The following is a description of a gene set: Human Gene Set: GOBP_POSITIVE_REGULATION_OF_DENDRITIC_SPINE_DEVELOPMENT Any process that increases the rate, frequency, or extent of dendritic spine development, the process whose specific outcome is the progression of the dendritic spine over time, from its formation to the mature structure. species: Homo sapiens, and this is the list of marker genes: IL1RAPL1, DLG5, MAPK6, CPEB3, ITSN1, CAMK1, ZMYND8, CFL1, MAPKAPK5, SHANK1, CAPRIN2, APOE, EPHB2, RELN, BAIAP2, NLGN1, GPRASP3 (NCBI Gene Id 80823), PTPRD (NCBI Gene Id 5789), FMR1, CAPRIN1, NLGN2 (neuroligin 2, NCBI Gene Id 57555), STAU2, IL2, ARMCX5-GPRASP2, NEURL1, EEF2K, LLPH, C21orf91, RAC1, PSEN1, SHANK3, LRP8, CUX2, SLC30A1, DBN1, LPAR1, ITPKA, CAMK2B, DHX36, PAFAH1B1, FOXO6